Given this list of marker genes Nck1, Hif1a, Txndc12, Src, Taf6, Rtkn2, Cyld, Atad5, Kdm6a, Nono, Plagl2, Atf4, Eif2ak3, Bbc3, S100a8, Kdm1a, Ptgs2, Wfs1, Nme5 (NME/NM23 family member 5), Pmaip1, Pink1, Hnrnpk, Il10, Dnaja1, Bcl2, Pias4, Gpx1, Ddit3, App (NCBI Gene Id 319425), Ackr3, Siah1a, Snai1, Bag5, Ern1, Fbh1, Ndufs3, Ikbkg, Bcl2l12, Wnt1, Parl, Tifab, Parp1, Prodh, Eno1 (NCBI Gene Id 269605), Fbxw7, Fcgr2b, Bdkrb2, Ell3, Ubb, Mtch2, Sh3glb1, Cyct, Mmp9, Sod1, Bid, Vdac2, Pdx1, Nox1, Lrrk2, Spop, Ptpmt1, Fgf2, Ivns1abp, Mdm2, Hspb1, Steap3, Trp53, Usp47, Syvn1, Nkx3-1, Ctnnb1, Dnm1l, Hyou1, Nherf1, Rps7, Ripk3, Erp29, Bcap31, Bad (BCL2-associated agonist of cell death), Rps3 (NCBI Gene Id 52418), Mapk8ip1, Pycr1 (pyrroline-5-carboxylate reductase 1), Hdac1, Becn1, Ndufa13, Siah1b, Ddias, Cxcl12, Sirt1, Rad9a, Marchf7, Herpud1, Usp15, Sfpq, Bcl2l10, Ddx3x, Pik3cb (NCBI Gene Id 74769), Rrn3, Il20ra, Nck2, Map2k1, Cd44, Hdac2, Grina, Trim32, Flcn, Zfas1, Bclaf1, Fzd1, Gcg, Armc10, Selenos, Septin4, Ptpn1, Tpt1 (tumor protein, translationally-controlled 1), Fyn, Pycard, Ptpn2, Rnf183, Bub1, Pttg1ip, Adcy10, Akt1 (thymoma viral proto-oncogene 1), Mmp2, Gsdme, Bcl2l11, Cd74, Dapk2, Ccar2, Cav1, Nol3, Gata4, D1Pas1, Mif, G2e3, Ubqln1, Opa1, Rack1 (receptor for activated C kinase 1), Xbp1, Snai2, Il19, Rpl26, Prkn (parkin RBR E3 ubiquitin protein ligase), Knl1, Lck, Bmyc, Bax, Noc2l, Sod2, Bok, Skil, Trem2, Park7, Fbxo7, Prkra, Creb3l1, Cdkn2d (cyclin dependent kinase inhibitor 2D), Nupr1, Zfp385a, Epo, P4hb, Ei24, Mcl1, Cep63, Ybx3, Triap1, Trp73, Tmem161a, Eif2a, Ankrd2, Plscr1, Creb3, Eno1b, Mdm4, Mapk7, Msx1, Vnn1, Myc, Trap1, Clu, Fis1, Tmbim6, Plaur, Rrm2b, Hells, Styxl1, Muc1, Uri1, Serinc3, Ppia, S100a9, Nfe2l2, Nacc2, Ppif, Fignl1, Bcl2l1, here is a description of the gene set: Any process that modulates the frequency, rate or extent of intrinsic apoptotic signaling pathway. Mouse Gene Set: GOBP_REGULATION_OF_INTRINSIC_APOPTOTIC_SIGNALING_PATHWAY studied in species Mus musculus